The following is a description of a gene set: Genes negatively differentially expressed in cell type: γδ T cell upon treatment with cytokine: IFN-κ in mouse lymph nodes in vivo. species: Mus musculus Cytokines mediate cell-cell communication in the immune system and represent important therapeutic targets. A myriad of studies have highlighted their central role in immune function, yet we lack a global view of the cellular responses of each immune cell type to each cytokine. To address this gap, the authors created the Immune Dictionary, a compendium of single-cell transcriptomic profiles of more than 17 immune cell types in response to each of 86 cytokines (>1,400 cytokine-cell type combinations) in mouse lymph nodes in vivo. A cytokine-centric view of the dictionary revealed that most cytokines induce highly cell-type-specific responses. For example, the inflammatory cytokine interleukin-1β induces distinct gene programmes in almost every cell type. A cell-type-centric view of the dictionary identified more than 66 cytokine-driven cellular polarization states across immune cell types, including previously uncharacterized states such as an interleukin-18-induced polyfunctional natural killer cell state. from publication Cui A, Huang T, Li S, Ma A, Pérez JL, Sander C, Keskin DB, Wu CJ, Fraenkel E, Hacohen N (PMID 38057668) Mouse Gene Set: CUI_T_CELL_GD_IFNK_RESPONSE_DN, and this is the list of marker genes: Ppp1r15a, Dusp1, Fos, Klf2, Rhob, Gadd45b, Klf6, Ube3a (NCBI Gene Id 76097), Hspa1b